Given this list of marker genes CRKL, CD99L2, TRIM55, ITGA4, CRK, FER, PECAM1, here is a description of the gene set: Human Gene Set: GOBP_DIAPEDESIS species: Homo sapiens The passage of a leukocyte between the tight junctions of endothelial cells lining blood vessels, typically the fourth and final step of cellular extravasation.